The following is a description of a gene set: Tumor growth is associated with a profound alteration of myelopoiesis, leading to recruitment of immunosuppressive cells known as myeloid-derived suppressor cells (MDSCs). Analyzing the cytokines affecting myelo-monocytic differentiation produced by various experimental tumors, we found that GM-CSF, G-CSF, and IL-6 allowed a rapid generation of MDSCs from precursors present in mouse and human bone marrow (BM). BM-MDSCs induced by GM-CSF+IL-6 possessed the highest tolerogenic activity, as revealed by the ability to impair the priming of IFN- -producing CD8+ T cells upon in vivo adoptive transfer. Moreover, adoptive transfer of syngeneic, GM-CSF+IL-6-conditioned MDSCs to diabetic mice transplanted with allogeneic pancreatic islets resulted in long term acceptance of the allograft and correction of the diabetic status. Cytokines inducing MDSCs acted on a common molecular pathway. Immunoregulatory activity of both tumor-induced and BM-derived MDSCs was entirely dependent on C/EBP transcription factor, a key component of the emergency myelopoiesis triggered by stress and inflammation. Adoptive transfer of tumor antigen-specific CD8+ T lymphocytes resulted in therapy of established tumors only in mice lacking C/EBP in myeloid compartment. These data unveil another link between inflammation and cancer and identify a novel molecular target to control tumor-induced immune suppression. We used gene expression analysis to identify those factors, secreted by tumor-infiltrating MDSC, which could drive emathopoiesis. Moreover we compare gene expression profile of tumor-induced MDSC, obtained from either the spleen and the tumor infiltrate of tumor bearing mice, and in vitro bone marrow-derived MDSC. Human Gene Set: GSE21927_SPLENIC_C26GM_TUMOROUS_VS_4T1_TUMOR_MONOCYTES_UP from publication Marigo I, Bosio E, Solito S, Mesa C, Fernandez A, Dolcetti L, Ugel S, Sonda N, Bicciato S, Falisi E, Calabrese F, Basso G, Zanovello P, Cozzi E, Mandruzzato S, Bronte V (PMID 20605485) Genes up-regulated in CD11b+ cells from spleen of BALB/c mice bearing C26GM colon carcinoma versus CD11b+ cells from tumors of BALB/c mice bearing 4T1 mammary carcinoma. species: Homo sapiens, and this is the list of marker genes: PRDM5 (PR/SET domain 5), UPK2, ITPRIP, SRSF1, URB1-AS1, C15orf61, CAPN14, NFATC3, KRTAP2-1 (NCBI Gene Id 81872), ANXA2P1, PFKFB3, PLXNA4, SPINK1, HIGD1A, SEC22C, TRPV5, CDK2AP2, LCA5L, SEC23A, PDGFRA, SNED1, ACTN3, SPACDR, COX4I2, SLC5A1, PSMC3, PTH2, SMR3B, ASPM, C1QA, CKB, IFNLR1, RBP7, PDE6D, TFAP2A, ZNF718, HRK, SDHAF1, P2RY6, C1orf116, GPR32, ATXN3L, PI3, H2AJ, KCNAB1, TEAD3, NHERF2, RNF157, ZMYND10, SLC19A2, PKP4, DEFB114, MARF1, SNX30, ZNF804A, CFD, RRBP1, LHFPL2, SLC43A1, ZKSCAN5, CHFR, CYSTM1, BRD8, TUSC2, STX1B, SHPRH, GMCL1, MARVELD3, MT1H, AACSP1, F11R, RSPRY1, SMIM21, CKS2, CFAP20, IGKV1D-13, FAM30A, FAM91A1 (NCBI Gene Id 157769), EPS15, PDZRN3, ZNF491, TIMP3, LPAR6, ACSM3, VTI1A, NFE2L1, STAG3, LINC01619, LRRD1, CCHCR1, SKIL, SHF, VGLL2, LZTFL1, PRKAG2-AS1, PTPN21, CNRIP1, FANCI, FGR, ZNF524, ZNF815P, PTPRM, EXTL1, SCGB2B2, CCDC136, COL4A1, HYCC2, GPM6B, FGFR4, RPRD1A, LINC00857, PITPNA, FBXL22, FLACC1, HTR3C (5-hydroxytryptamine receptor 3C), TMEM229B (transmembrane protein 229B, NCBI Gene Id 161145), ID3, TTTY2, LPIN2, AP4S1, HEXB, CTAG2, HSPA1L, ZNF490, ASF1B (NCBI Gene Id 55723), KMT5A, SMPD1, SH3GL1P2, MICALL2, NFU1, PLEKHG5, ATOSB, S1PR5, TCF20, CLIP4, AXDND1, COL14A1, POLD1, BAG2, CUZD1, PRR23E, NSUN7, MISP, KLF17P1, POPDC2, IQCF5-AS1, VPS37A, DIRAS3, CIDEC, ME1, NUMB, PLPPR5-AS1, UBA3, NOD2, ENSG00000291179 (NCBI Gene Id 554206), NUP210L, CAPZA1, EIF2B4, RUNDC1, MYADM, KMT2A, SERPINB9, RASL11A, USP53, N4BP2L1, BCKDHA, MZF1-AS1, LINC01242 (NCBI Gene Id 650033), SPP1, PRSS53, SLC5A11, S100A10, CDKN2D, CTSW, ILF3-DT, ITM2B, DLG3, TOB1, WSCD2, GPN2, RGS22, CHAD, FBXO42 (NCBI Gene Id 54455), PCNA